Given this list of marker genes DCT, CRY2, CPT1B, CRY1, OPN3, TYR, LCN2, here is a description of the gene set: studied in species Homo sapiens Any process that results in a change in state or activity of a cell or an organism (in terms of movement, secretion, enzyme production, gene expression, etc.) as a result of a blue light stimulus. Blue light is electromagnetic radiation with a wavelength of between 440 and 500nm. Human Gene Set: GOBP_RESPONSE_TO_BLUE_LIGHT